Given this list of marker genes Scaf1, Lhx6, Esco1, Tgfb2, 1110018N20Rik, Slamf9, Shroom3, Rora, A930012O16Rik, Spice1, Dbn1, Taf3, Tln1, Scp2, Brip1os, Zdhhc5, Ino80d, Ino80dos, Spink10, Zbtb38, Psme1, Brip1, Creb3, Mybbp1a, 4930578M01Rik, Kcnb1, Taf4b, Ubald1, Diaph2, Peg13, Gm8524, here is a description of the gene set: from publication Yevshin I, Sharipov R, Kolmykov S, Kondrakhin Y, Kolpakov F (PMID 30445619) Mouse Gene Set: ZFP989_UNIPROT_H3BLB0_UNREVIEWED_TARGET_GENES studied in species Mus musculus